The following is a description of a gene set: Mouse Gene Set: GOBP_REGULATION_OF_MACROPHAGE_CYTOKINE_PRODUCTION species: Mus musculus Any process that modulates the rate, frequency or extent of macrophage cytokine production. Macrophage cytokine production is the appearance of a chemokine due to biosynthesis or secretion following a cellular stimulus, resulting in an increase in its intracellular or extracellular levels., and this is the list of marker genes: Mapkapk2, Tlr4, Tlr7, Laptm5, Tlr2, Casp4, Tgfb2, Nlrx1, Acp5, Rtn4, Cuedc2, Atg9a, Panx1, Cd36, Gprc5b, Ticam1, Sema7a, Mir324, Sirt1 (sirtuin 1), Litaf, H2-M3, Axl (NCBI Gene Id 26362), Pycard, Tlr3, Psg22, Nod1, Card9, Spon2, Prg2, P2rx7, Tgfb3, Wnt5a, Myd88, Casp1, Twist2, Epx, Ube2j1, Ifng, Ripk2, Tgfb1 (NCBI Gene Id 21803), Cd74, Plcg2, Twist1, Nod2, Irak3, Tirap